Given this list of marker genes LOXL2, ZNF704, ZMIZ1, BLMH, HBP1 (NCBI Gene Id 26959), C2orf68, C1QTNF6, AKAP5, PPP1R13B, COL4A2, RARB, RGS1, TFEC, IQCJ-SCHIP1, DIO2, KIAA1549, DGKD, COL11A1, PCGF3, PI15, MORF4L2, SPPL2B, COL3A1, TMOD3, ZNF469, SLC30A3, GPR37, SERINC5, GIT2, ATRN, STMP1, ZBTB5, FAM168B, RNF39, VPS37C, GNG12, COL27A1, NREP, SLC5A8, PGAP2 (NCBI Gene Id 27315), COL1A2, KIF26A, FGD4, PRR3, TMEM178B, SPARC, TLCD3B (TLC domain containing 3B), REDIC1, LSM11 (LSM11, U7 small nuclear RNA associated), TMTC3, SLC6A14, ADAMTS10, ABCE1, TNFAIP3, AK4, CCNT2, ELF2, PCDHAC1, ADAMTS17, SNX24, FRAT2, PXYLP1, PPIC, MED12L (NCBI Gene Id 57726), CD276, COL15A1, RLF, MAP6, LAMA2, NUP160, PCDHA12, ZNF282, YBX3, GID8, DENND6A, MTMR4, PRR14L, SCML2, HIF3A, PRRC2C, STX16 (syntaxin 16), SAMTOR, BAK1, RAPGEFL1, COL22A1, RHOBTB1, MFAP3, COL19A1, IREB2, MAP4K4, TMEM236, METAP2, ZNF512B, CDC42BPA, TRAF4, BCCIP, CREB5, HAPLN3, HBEGF, LASP1, SHPRH, PALM, DYNLT1, SH3GLB1, EIF4E2, FAM13B, COL4A1, NPAS3, DGKH, C10orf55, MAPK10, MAPRE1, OSTC, SGCZ, BMF, REST, C5orf15, ZFP91, PXDN, FER, REV3L, GRIA3, ZFX, CPS1, FBXW7, TNFRSF1A, NKTR, YTHDF3, TRIM63, CEMIP, PMP22, PCDHA1, TMEM169, RAP1A, SIDT2, ARHGEF10, EFNA5, CBX6, NASP, ADAMTS2, RNF138, PCDHA5, JAZF1, N4BP2L1, ELOVL4, CRISPLD1, OTULIN, TET2, SMTNL2, COL25A1, TTC9, BCORL1, NAV1, SETDB1, PCDHA10, MORF4L1, TMEM65, NEXMIF, UBFD1, PAPOLG, SP1, RMND5A, CLEC2L, LAMC1, CEP97, MAPKBP1, ING3, USP34, EOMES (eomesodermin), MINAR1, ISG20L2 (interferon stimulated exonuclease gene 20 like 2), CPSF7, IGF1, ENPP2, NAV2, ATP1B4, TMEM183A (transmembrane protein 183A), XKR7, FOXJ2, HAS3, TAF5, OTUD4, XKR4, NAP1L3, SLC7A6, CNR1 (cannabinoid receptor 1), RFX7, IL1RAP, ERCC6, SLC44A5, GABRP, SSC4D, SEC24D, REL, TRIB2, SIDT1, ARPP19, LPL, CDC42, COL5A1, PAN2, DNMT3B, NKAPD1, NSD1 (nuclear receptor binding SET domain protein 1), JARID2, TNRC18, KIF26B, HMCN1, CAMK4, CCSAP, MATCAP2, ROBO1, SMIM17, PCDHA4, ADAMTS9, RAP1GDS1, TET3, IFFO1, LYSMD1 (NCBI Gene Id 388695), RND3, DICER1, ZHX3, EML5, HPGD, COL7A1, MBTD1, SERPINH1, DCX, B3GNT5, STX17, ANTXR2, DAAM1, MARCHF1, KDM5B, LIF, NCKAP5, ZNF28, ZMYM2, AMER1, VASH1 (vasohibin 1), ERLIN2, FAM167A, ULBP2, NKRF, FBN1, COL4A5, ZBTB20, EPC1, DDX3X (DEAD-box helicase 3 X-linked), SH3PXD2A, LOX, PCDHA7, POLR3E, PGAP1, DNMT3A, MYBL2, KIF24, DAAM2, CAMSAP2, TAF11, PURG, LYPLA1, COL5A3, HRK, AKT3, BTG2, COL1A1, IFI30, TIMM8B, ADAMTS7, CPEB3, KLHL28, KCTD20 (NCBI Gene Id 222658), FAM241A, BACH2, WWTR1, FERMT2, SMS (NCBI Gene Id 6735), MLXIP, FREM2, CSGALNACT2, ABHD18, GRIP1, DOLPP1, KNOP1, CCNYL1, TUBB2A, CLDN1, SH3BP5L, EIF3J, PCDHA6, EML6, BRWD3, LOXL4 (NCBI Gene Id 84171), SETDB2, KCTD5, RNF19A, MCL1, PRPF40A, MGA, HDAC4, PCDHA2, PIK3R1, GPATCH2, COL4A6, FEM1B, CLOCK, SMPD3, ZNF346, RERE, DPYSL5, ATP2B4 (NCBI Gene Id 54594), RTL6, ARVCF, MOB1A, CSRNP2, PRKG1, ASAP2, RAB30, PTBP3, ZFP36L1, NOTCH2, PTPRK, COL5A2, GXYLT2, FBXW9 (F-box and WD repeat domain containing 9), ERP44, SHROOM2, RBAK, ASXL3, MIDEAS, CDK6, ADAMTS6, STMN2, MYCN, GPX7, PRKAB2, PARG, CCSER2, EML4, SGK1, ATAD2B, DTWD2, SAMD4A, MEX3B, XKR6, CHSY1, PCDHA9, USP37, NKIRAS2, HAPSTR1, REPS2, NAV3, KLF4, TFEB, ICOS, AMMECR1L, LIN7A, CCNJ, AKAP13, OSBPL11, ETV6, ELN, GAB1, CRYBG1, USP6NL (NCBI Gene Id 9712), RIC1, DVL3, PCDHA13, ING2, CAV2, SENP1, PDIK1L, WDFY1, ANKRD13C, INA, ZDHHC21, PCDHA11, COL9A1, NFIA, SESTD1 (NCBI Gene Id 91404), MUC22, NFAT5 (nuclear factor of activated T cells 5), POGLUT2, FRAS1, PPP1R15B, DCUN1D4 (NCBI Gene Id 23142), DCAF7, PCDHA8, TFAP2C, DOT1L, SS18L1, HORMAD1, PAIP2, COL4A4, MXD1, CEP68, COL6A3, TRAF3, ENHO (NCBI Gene Id 375704), VEGFA, NLRX1, TPK1, AKAIN1, SLC16A14, FSTL1 (follistatin like 1), PPM1E, HS3ST3B1, ANKRD13B, TDG, TLL1, TCF4, KMT5C, TET1, COL2A1 (collagen type II alpha 1 chain), SGMS2, CUEDC1, PINX1, SIRT1, GNB4, PTEN, DLG2, PCSK5, ZBTB10, AKT2, ZBTB34 (NCBI Gene Id 403341), STRN4, DTX4, PCDHA3, MAPRE2, C11orf54, PLP1, PCDHAC2 (protocadherin alpha subfamily C, 2), JMY, here is a description of the gene set: Genes predicted to be targets of miRBase v22 microRNA hsa-miR-29a-3p in miRDB v6.0 with MirTarget v4 prediction scores > 80 (high confidence targets). Human Gene Set: MIR29A_3P studied in species Homo sapiens from publication Chen Y, Wang X (PMID 31504780)